Given this list of marker genes Nek6, Snai1, Avpr2, Gas5, Atf7ip, here is a description of the gene set: Mouse Gene Set: BAFNA_MUC4_TARGETS_UP species: Mus musculus Numerous studies have established the association of MUC4 with the progression of cancer and metastasis. An aberrant expression of MUC4 is reported in precancerous lesions, indicating its early involvement in the disease process; however, its precise role in cellular transformation has not been explored. MUC4 contains many unique domains and is proposed to affect cell signaling pathways and behavior of the tumor cells. In the present study, to decipher the oncogenic potential of MUC4, we stably expressed the MUC4 mucin in NIH3T3 mouse fibroblast cells. Stable ectopic expression of MUC4 resulted in increased growth, colony formation, and motility of NIH3T3 cells in vitro and tumor formation in nude mice when cells were injected s.c. Microarray analysis showed increased expression of several growth-associated and mitochondrial energy production-associated genes in MUC4-expressing NIH3T3 cells. In addition, expression of MUC4 in NIH3T3 cells resulted in enhanced levels of oncoprotein ErbB2 and its phosphorylated form (pY(1248)-ErbB2). In conclusion, our studies provide the first evidence that MUC4 alone induces cellular transformation and indicates a novel role of MUC4 in cancer biology. Genes up-regulated in NIH3T3 cells (fibroblast) engineered to stably express MUC4. from publication Bafna S, Singh AP, Moniaux N, Eudy JD, Meza JL, Batra SK (PMID 19010895)